The following is a description of a gene set: The series of molecular signals initiated by an extracellular ligand binding to the receptor Toll on the surface of a target cell, and ending with the regulation of a downstream cellular process, e.g. transcription. Mouse Gene Set: GOBP_TOLL_SIGNALING_PATHWAY studied in species Mus musculus, and this is the list of marker genes: Irak4, Peli2, Traf3, Sigirr, Peli3, Irak3, Irak2, App, Peli1, Palm3, Nlrp12, Myd88, Irak1